Given this list of marker genes Lep, Oprm1, Tacr2 (tachykinin receptor 2), Smad4, Foxl2, Crh, Ucn2, Kiss1, Oprk1, Crhr2, here is a description of the gene set: species: Mus musculus Any process that modulates the frequency, rate or extent of the regulated release of luteinizing hormone. Mouse Gene Set: GOBP_REGULATION_OF_LUTEINIZING_HORMONE_SECRETION